Given this list of marker genes RRP1, NT5C, SLC17A9, SSX5, NIF3L1 (NGG1 interacting factor 3 like 1), IL1B, DNM2, PIF1, ARPC4, TMEM259, C19orf81, KNDC1, NBEA, SMARCD2, FBXO21, TFDP2, EPRS1, CREB3L1, MRPL28, XIST, PLA2G4C, ATP7B, NDRG2 (NDRG family member 2), TDRD1, RNF208, PRXL2B, HRAS, IRF2BPL (interferon regulatory factor 2 binding protein like), SLC16A8 (solute carrier family 16 member 8), IQCH, CFHR1, MPP3, NDUFA10, DENND5A, TBC1D16, GPSM1, AJAP1, IGF2BP2, FBXL16, TNFRSF4, NHEJ1, MLX, SPINT1, TRNAU1AP, CACNG2, LELP1, SHROOM2, CCDC18, MPZL2, TKTL2, PAFAH1B3, TWF2, CBX5, SORCS3-AS1, UGT2B4, TTLL8, KCNC1, IER5, IHH, FASTKD2, ELAPOR1, TREX2, CHIA, CTDSP1, C1QTNF7, UNC119, CPA3, APOB, SLC15A1, GRHPR (NCBI Gene Id 9380), TMEM107, CSPG5, ACOT4, KRTCAP2 (keratinocyte associated protein 2), RNF148, TPD52L1, DNAJC11, TAGLN2, TBC1D20, LRP8, MAGEB4, NPRL2, SLC23A1, NFRKB, ALKBH2, BPIFC, PRMT9, HLA-DOA, TRAPPC6A, AIRN (NCBI Gene Id 100271873), PPP1R3C, RBM28, CHRM4, RNF167, AGPAT2, CHCT1, NRG3, NACC2, GPD1L, FSIP1, GAS6, KCNK6, WDR18 (WD repeat domain 18), SAMD4B, TUBD1, CYP24A1, NDUFB2, SLC26A8, TNFRSF18, PENK, ARG1, METTL18, ARHGAP11A, GPAA1, TMC1, MYO10, FRRS1, SERPINH1, HSD17B7, SLC5A11, CTU1, POSTN, SLC66A3 (NCBI Gene Id 130814), SLC40A1, SERAC1, SLC35E4, C5orf24, UQCR11, SH3BP5, H6PD, HEG1, EZH2, PIP5K1B, ZNF385C, SPRR2F, TRIM72 (tripartite motif containing 72), EIF2B2, GLYCTK, AIRE, PGP, CWH43, FCGRT, MPZL3, PYGM, LRP1B, DOK7, CAPG, CLEC5A, RNF217, RAB39A, TNFAIP1, MKS1, ADD2, ERCC4, LGALS1, MRPL11, REX1BD (NCBI Gene Id 55049), STK40, INTS14, CTNNA2, DYRK3, RNASEH2C, MAPKAPK3, IRAK2, GNG10, MVK, SLC5A7, CMC2, GRM1, TBX1, SMKR1, CLDN15, NPAS1, RYR2, EMILIN3, ABRAXAS2, PCLO, C11orf68, PLCB3, AQP7, GHDC, VKORC1, UQCC5, EPS8L1, SUMF1, GPR61, PCDH11X, GRPR, MVD, CFAP299, TMEM176A, TMEM41B, FAM241A, THAP7, ARL6IP1, ADGRL2, NME4, RALYL (RALY RNA binding protein like), OAZ3, here is a description of the gene set: species: Homo sapiens Human Gene Set: GSE2770_TGFB_AND_IL4_VS_TGFB_AND_IL12_TREATED_ACT_CD4_TCELL_6H_UP Genes up-regulated in CD4 T cells activated by anti-CD3 and anti-CD28: TGFB1 and IL4 (6h) versus TGFB1 and IL-12 (6h). Th1 and Th2 cells arise from a common precursor cell in response to triggering through the TCR and cytokine receptors for IL-12 or IL-4. This leads to activation of complex signaling pathways, which are not known in detail. Disturbances in the balance between type 1 and type 2 responses can lead to certain immune-mediated diseases. Thus, it is important to understand how Th1 and Th2 cells are generated. To clarify the mechanisms as to how IL-12 and IL-4 induce Th1 and Th2 differentiation and how TGF-beta can inhibit this process, we have used oligonucleotide arrays to examine the early polarization of Th1 and Th2 cells in the presence and absence of TGF-beta after 0, 2, 6 and 48 hours of polarization. from publication Lund R, Aittokallio T, Nevalainen O, Lahesmaa R (PMID 14607935)